The following is a description of a gene set: studied in species Mus musculus Stromal cell lines represent an exceptional tool to study the role on the microenvironment on hematopoietic stem cell (HSC) activity. We have compared the expression profile of HSC supportive vs non-supportive stromal lines generated from different hematopoietic tissues in the mouse, i.e the aorta-gonad-mesonephros (AGM) region, the fetal liver and the adult bone marrow, sequentially activated during development. In this study, six stromal lines were used with one HSC supportive and one non-supportive for each tissue (triplicate samples for each stromal line). We used Mouse Gene 1.0 ST microrrays in combination with GSEA and statistical analysis to identify lists of genes that segregate HSC supportive from non-supportive stromal lines. Genes up-regulated in the HSC non-supportive stromal cell lines. Mouse Gene Set: DURAND_STROMA_NS_UP, and this is the list of marker genes: Dusp16, Prelid3a, Prrg4, Gch1, Coa3, Atrnl1, Gprc5a, Ralgapa2, Pcdh9, Nanos1, Lpar2, Aldh7a1, Hivep2, Rexo4, Ampd3, Arnt2, Gdf15, S1pr3, Exoc6, Tle4, Wbp11, Tmem170b, Llgl2, Gpx7, Ezr, Bicd1, Gpr39, Phyh, Myl9, Rundc3b, Bnc1, Gpr149, Itpr1, Slfn3, Ucp2, Sash1, Sh3rf3, Tnfsf9, Fam110c, Lfng, Rcor2, Gata6, Abhd6, Fblim1, Jam2, 4930486L24Rik, Cmbl, Pbp2, Aim2, Ovgp1, Gata4, F2r, Fzd7, Nox4, Trmt61b (NCBI Gene Id 68789), Foxred2, Wdr31, Dmpk, Zfp595, Brinp3, Etl4, Slc4a8, Tmem266, Zswim6, Pde3b, Gdpd1, Slc16a3, Rab6b (RAB6B, member RAS oncogene family), Ctsk, Tmem45a, Atoh8, Fez1, Srd5a1, Rab27b, Rnf128, Krt19, Cryab, Snai1, Ly9, Stag3, Klf4, Gpr176, Ptprg, Plcb1, Il1rl2, Elovl4, Nod1, Rbpms, Car12, Map3k6, Alkbh7, Acsbg1, Nrep, Dnph1, Sh3bp5, Syngr3, Cep126, H2-K1, Ptpn13, Zfp503, Peg12, Aig1, 2310030G06Rik, Rbm12b1, Wnk3, Tmem141, Tmem109, Wwc1, Lpcat4, Pik3r5, H2aj, Rbks, Mrps31, Scamp5, Rbm47, Cpa6, Dusp6, Dcn, Fetub, Havcr2 (NCBI Gene Id 268402), Chn2, Slc35g1 (solute carrier family 35, member G1), Mlf1, Slc16a13, Mfsd2a, Dnajc27, Stxbp2, Prex2, Ica1, Epor, Osr1, Hs3st1, Naip2, Lmo7, Slc2a3, Parm1, Glipr1 (NCBI Gene Id 73690), Tcf7, Ddx19b, Slc35b4, Insl6, 2900026A02Rik, Creb5, Grem2, Olr1, Hhat, Slc25a33, Nipsnap1, Hectd2 (NCBI Gene Id 226098), Arhgap26, Lipo3, Lpar6, Adamtsl3, Grem1, Zfp979, Tmem185b, Ctsc, Mpp7 (membrane protein, palmitoylated 7 (MAGUK p55 subfamily member 7)), Vstm5, Foxq1, Dmrt2, Zfp593, Tnfsf13b, Man1a, Mrpl35, Prkag2, Gjb3, Nedd9, Spry4, Unc5b, Mt2, Zfp518b